Given this list of marker genes CLCNKB (NCBI Gene Id 1188), NR3C2, SCNN1A, KCNJ1, CLCNKA, SLC12A1, BSND, SLC26A3, here is a description of the gene set: An abnormally increased activity of the renin-angiotensin system, causing hypertension by a combination of volume excess and vasoconstrictor mechanisms. studied in species Homo sapiens Hyperactive renin-angiotensin system Human Gene Set: HP_HYPERACTIVE_RENIN_ANGIOTENSIN_SYSTEM